Given this list of marker genes TRPV4, VSTM2A, HNRNPU, MAPK14, INS, RREB1, BMP7, TFE3, METRNL, GATA2, PTGS2, PIM1, MIR128-1, NAPEPLD, SOX13, LEP, FNDC5, SIRT1, SLC7A10, SIX1, DUSP10, ZBTB7B, FFAR4 (free fatty acid receptor 4), FTO, FLCN, here is a description of the gene set: Any process that modulates the rate, frequency, or extent of brown fat cell differentiation. Brown fat cell differentiation is the process in which a relatively unspecialized cell acquires specialized features of a brown adipocyte, an animal connective tissue cell involved in adaptive thermogenesis. Brown adipocytes contain multiple small droplets of triglycerides and a high number of mitochondria. Human Gene Set: GOBP_REGULATION_OF_BROWN_FAT_CELL_DIFFERENTIATION studied in species Homo sapiens